Given this list of marker genes Mapre1, Stmn1, Gba2, Mapt, Clip1, Gda, Psrc1, Arhgef7, Slain2, Kif21a, Rps3, Stmn2, Arl2, Cav1, Sgk1, Cdk5rap2, Slain1, Camsap3, Apc, Togaram1, Cav3, Fkbp4, Dctn1 (dynactin 1), Git1, Dyrk1a, Prune1, Mapk8, Map2, Rac1, Camsap2, Clasp2 (CLIP associating protein 2), Nav3, Map1b, Clip3, Abl1 (NCBI Gene Id 98922), Snca (NCBI Gene Id 20617), Pak1, Inpp5j, Camsap1, Cdkn1b, Drg1, Hspa1b, Pde4dip, Cdh5, Tubb4a, Hspa1a, Akap9, Nme7, Mecp2, Met, Slc39a12, Ankrd53, Tbcd, Numa1, Eml2, Mapre3, Ckap5, Fes, here is a description of the gene set: Mouse Gene Set: GOBP_REGULATION_OF_MICROTUBULE_POLYMERIZATION Any process that modulates the frequency, rate or extent of microtubule polymerization. species: Mus musculus